The following is a description of a gene set: studied in species Mus musculus Mouse Gene Set: GOBP_RESPONSE_TO_ETHANOL Any process that results in a change in state or activity of a cell or an organism (in terms of movement, secretion, enzyme production, gene expression, etc.) as a result of an ethanol stimulus., and this is the list of marker genes: Pax6, Ctsk, Fyn, Mir9-1, G6pd2, Fgf15, Trp53inp1, Arsa, Tbxas1, Nppc, Rgs2, Fosb, Hmgcs2, Usp46, Setd7, Ncam1, Adipor2 (adiponectin receptor 2), Glra3, Prkcb, Tnc, Glra2 (glycine receptor, alpha 2 subunit), Bcl2, Gabbr1 (NCBI Gene Id 54393), Ogg1, Grin1, Dnmt3a, Cnr1, Nr0b2, Adh7, Cpt1a, Crh, Ptk2b, Aacs, Adipoq, Nlrp3 (NLR family, pyrin domain containing 3), Avp, Sod2, Mir200a, Cldn7, Lep, Penk, Itpr2, Gria1, Csf3, Abat, Gata3, Mir339, Alad, Slc10a1, Mir296, Cldn1, Elk1, Cdo1, Crhr1, Mir362, Maob, Htr1b, Slc23a2, Birc2, Mir10a, Mir10b, Mir29c, Trh, Eif4g1, Mir145a, Tgfb1, Igf1r, Sirt1, mt-Nd4, Fos, Vhl, Mir9-3, St6gal1, Dmap1, Kcnc2, Cybb, Tnfrsf11a, Shh, Star, Lct, Dbh, Eef1b2, Casp8, Tbxa2r, Ugt1a1, Rps6-ps4, Drd2, Arc, Mir496a, Th, Cyp7a1, Oprm1, Phb1, Kcnmb1, Tufm, mt-Cytb (NCBI Gene Id 17711), Gstp1, Grin2b, Prkce, Eps8, Bak1, Myd88, Hspa8, Got2, Tjp1, Ccl7, Srebf1, Ccl2, Creb1, Slc6a3, Cat, Adcy7, Adh1, Gk, Sod1, Slc2a4, Chrna7, Gnrh1, Nqo1, Tyms, G6pdx, Crhbp, Cldn18, Tlr4, Atp5f1a, Fgf2, Il2, Mstn, Cldn5, Mir152, Apobec1, Ggh, Rps6, Abcb11, Oprd1 (opioid receptor, delta 1), Mir9-2 (NCBI Gene Id 723967), Aldh2, Rps6kb1, Tnf, Cbl, Hoxa1, Igf1, Adcyap1, Sdf4, Cdk1, Chrnb2, Polb, Psmd14, Actc1, Mir30a, Unc79, Glra1, Mir30e, Rela, Mir154, Cd14, Tacr1, Aldh1a1, Prkaa1, Ehmt2, Pten, Fech, Rara, Prkca (protein kinase C, alpha), Hpgd, Cldn3, Grin3a, Drd3, Ppara, Grin2a